The following is a description of a gene set: from publication Hahtola S, Tuomela S, Elo L, Häkkinen T, Karenko L, Nedoszytko B, Heikkilä H, Saarialho-Kere U, Roszkiewicz J, Aittokallio T, Lahesmaa R, Ranki A (PMID 16914566) Human Gene Set: HAHTOLA_MYCOSIS_FUNGOIDES_CD4_UP PURPOSE: Increased production of Th2 cytokines characterizes Sezary syndrome, the leukemic form of cutaneous T-cell lymphomas (CTCL). To identify the molecular background and to study whether shared by the most common CTCL subtype, mycosis fungoides, we analyzed the gene expression profiles in both subtypes. EXPERIMENTAL DESIGN: Freshly isolated cells from 30 samples, representing skin, blood, and enriched CD4(+) cell populations of mycosis fungoides and Sezary syndrome, were analyzed with Affymetrix (Santa Clara, CA) oligonucleotide microarrays, quantitative PCR, or immunohistochemistry. The gene expression profiles were combined with findings of comparative genomic hybridization of the same samples to identify chromosomal changes affecting the aberrant gene expression. RESULTS: We identified a set of Th1-specific genes to be down-regulated in Sezary syndrome as well as in a proportion of mycosis fungoides samples. In both Sezary syndrome and mycosis fungoides blood samples, the S100P and LIR9 gene expression was up-regulated. In lesional skin, IL7R and CD52 were up-regulated. Integration of comparative genomic hybridization and transcriptomic data identified chromosome arms 1q, 3p, 3q, 4q, 12q, 16p, and 16q as likely targets for new CTCL-associated gene aberrations. CONCLUSIONS: Our findings revealed several new genes involved in CTCL pathogenesis and potential therapeutic targets. Down-regulation of a set of genes involved in Th1 polarization, including the major Th1-polarizing factor, TBX21, was for the first time associated with CTCL. In addition, a plausible explanation for the proliferative response of CTCL cells to locally produced interleukin-7 was revealed. studied in species Homo sapiens Genes up-regulated in T helper cells (defines as CD4+) isolated from patients with mucosis fungoides compared to those from normal control donors., and this is the list of marker genes: SULT1A2, SOD2, RAB20, CXCL3, CHPT1 (NCBI Gene Id 56994), TRIB1, BTG2, ACTR2, MAPK14, EREG, ETS2, IER3, WIPI1, MCTP1, PRKAR1A, HBEGF, FUCA1, ADM, PTGS2, KIR3DL1, VNN1, EGR1, ENC1, CYRIA, CXCL8 (C-X-C motif chemokine ligand 8), MANBA, RIPK2, CCL4, LILRA5, PPP1R15A, NUP214, GLIPR1, ZNF185, CXCL2, KYNU, GLRX (NCBI Gene Id 90885), KLF6 (KLF transcription factor 6), NLRP3, RHOB, HLA-DRB4, G0S2, ABHD5, FBN2 (fibrillin 2), PFKFB3, MS4A4A, SLC16A6, EMC3, KLF4, CXCL1, H2BC21, IL1B (NCBI Gene Id 3553), BST2, ATF3, TMEM127, H2AC18, CDKN1A, GLUL, NEU1, PADI2, ARPC1A, CCL3, GM2A, PLAUR